Given this list of marker genes TSC22D4, PALM3, LRRC37B, TSPOAP1, NDUFS3, SYNGAP1 (synaptic Ras GTPase activating protein 1), FN3KRP, SEMA4D (semaphorin 4D), SNORD118, LINC01635, PAM16, SFT2D2, GCDH, LINC00869, ZBED5-AS1, RNU2-2P, RNU2-63P, ADGRG1, RPL32P3, LINC02251, RMRP, RNVU1-4, ADSS1, OXNAD1, NRSN2-AS1, DPF1, DAZAP1, MED22, RNU6-2, SNORD13, TMCC2, UBC, PITX2, CARD10, RNU2-17P, RNU11, RNVU1-21, CAPZA2 (NCBI Gene Id 830), ZNF260, SF3A3, MPP2, THRB, DIXDC1, TCP11L2, CHD4, SUPT7L, MIR5188, CPAMD8, CCDC97, VANGL1, WDR74, PCBP4, ITGB2, NR2F6, MIR4456, DPH3, FUS, RNU5D-1, PCGF3, SCCPDH, HDAC5, CDC42EP4, NT5DC3, RNU4ATAC, TSPOAP1-AS1, SET, CNOT2, ARHGAP6, ODR4, PRANCR, GNAQ, ASPSCR1, PCBP2, PTGES3, ZNF207 (zinc finger protein 207), GPANK1, DNAJB6P3, GNLY, YIF1B, MRPL43, LINC02868, CLEC10A, OSBPL2, TRMO, KDM5C, YARS2, CASC3, ENSG00000202269, TTC32-DT, MXI1, ZCCHC24, SARS2, SLC5A1 (NCBI Gene Id 6523), CALB2, PRSS22, GSTA4, SEPTIN5, RNVU1-2A, KDM3A, NUTM2A-AS1, ANXA2, PIH1D2, STXBP2, TWNK, ANP32E, FGD3, PRSS8, PLCD1 (phospholipase C delta 1), SCN5A, RNU6-8, SRSF3, RNU5B-1, TPI1P2, CSNK2B, PODNL1, PLIN3, RNVU1-23, RNU1-2, UBE2QL1, PDE4DIPP6 (PDE4DIP pseudogene 6), CTB-1I21.1, GID4, POU2F3, CASZ1, LINC02268, HEXIM1, ATAD2, SRFBP1, AOAH, GFI1B, GDF11, DIO3OS, P3H3, NDUFA2, ASB3, CLASP1, ENSG00000187951, SPOP, GFY, TTI2, RNU5A-8P, RNU5E-6P, POLDIP3, MRPL39, SANBR, ABCA7, SLC16A5, GNA15, KIRREL2, PARP2, CNOT6L, PCDH1, ANGPTL4, RNVU1-2, LACTB2, ARHGAP11B-DT, THUMPD3-AS1, SLC22A7, FAM138E, ETV4, NUMBL, CACFD1, ATP6V1D, KLHDC9, RN7SK (NCBI Gene Id 6028), DDX39B-AS1, SLC37A3, SPRED1, SP8, UBE2I, DNAJB4, CPT2, RAB7B, PLXNB1, NUP155, DDX39B, KMT5C (lysine methyltransferase 5C), CIC, RNU5E-1, RNY3, RNVU1-22, RNU5E-4P, ARSA, LMF1, KCNN4, FBXO24, RNVU1-25, ATPAF2, TMEM259, SRP54-AS1, OBSL1 (obscurin like cytoskeletal adaptor 1), FRS3, RPPH1, CCDC107, RNVU1-30, UBE2Q2P16, ZBED5 (zinc finger BED-type containing 5), ARRB2, PTK2B, TFAP2A, EFHB, NRSN2, KCTD10, PRPF3, PITRM1, C2CD2, MPHOSPH9, TTC32, RNU7-1, LINC01476 (NCBI Gene Id 101927728), LINC01671, ZNF565, RNU1-1 (RNA, U1 small nuclear 1), C17orf75, TSC1, SSR4P1, NPEPL1, C12orf57, CBFA2T3, RRBP1P1 (RRBP1 pseudogene 1), RNVU1-3, SLC8A2, UBE3B, CAPZA3, IK, ESPNL, SRRT, RNVU1-15, MECOM, ALKBH2, LINC02832, GYG1, RNU12, LRCH4, STAT6, RNU6-1, DCAF17, NIPAL1, MED16, BAGE2, ERCC1, INHA, RIMBP3B, THRB-AS1, TMCC3, CMSS1 (cms1 ribosomal small subunit homolog), RNFT2 (ring finger protein, transmembrane 2), RTBDN, CDK13, NDUFB9 (NCBI Gene Id 4715), ATP8A2, ERAP1, RNU6-419P, RNU6ATAC, RNU5F-1, RNU5A-1, ANKMY1, PLXDC1, FGD2, SPTBN4, KCNH2, CNGB1, BBX, AGAP3, GHET1, RNU6-9, RICTOR, SYNCRIP, PLK5, LINC02418, NCOR2, HMGCR, RIMBP3 (NCBI Gene Id 85376), RNY1, PBLD, ADARB1, SPSB1, RNVU1-28, SRP54, RNU1-108P, RASGRF2, JOSD2, COL6A2, RNVU1-19, TP53INP2, SYN3, LINC00339, ARHGEF1, NOD2, ELL, LINC01719, NECAP1, PTP4A2, CALY, BLK, RPL36, RPL7A, RNY4, TOM1, CNPY2, MIR100HG, ECE1, SUPV3L1, MIR4276, CCDC80, EIF2S1 (NCBI Gene Id 1965), KBTBD4, BTN2A2, FCHSD2, ENSG00000273727, SOX8, RNU6-7, CEROX1, RNVU1-34, RNVU1-6, TRAPPC9, MIR5087, TPR, CHAC2, PLCZ1, NKAPD1, VPS37D, RPAP3, TESMIN, SLC4A1AP, FAM27B, RNVU1-26, FTCD (NCBI Gene Id 10841), POGLUT1, ZNF146, YJU2, MIR548AW, METTL8 (methyltransferase 8, tRNA N3-cytidine), RNU4-1, CCNI, AVPR2, RAD52, RNU4-2, ETS2-AS1, PTH2, here is a description of the gene set: Human Gene Set: CDC5L_TARGET_GENES studied in species Homo sapiens Genes containing one or more binding sites for (CDC5L) in their promoter regions (TSS -1000,+100 bp) as identified by GTRD version 20.06 ChIP-seq harmonization. from publication Yevshin I, Sharipov R, Kolmykov S, Kondrakhin Y, Kolpakov F (PMID 30445619)